The following is a description of a gene set: The chemical reactions and pathways resulting in the formation of a phenol, any compound containing one or more hydroxyl groups directly attached to an aromatic carbon ring. species: Homo sapiens Human Gene Set: GOBP_PHENOL_CONTAINING_COMPOUND_BIOSYNTHETIC_PROCESS, and this is the list of marker genes: INSM1, PMEL, DDT, OPN3, TGFB2, ASIP, DCT, GATA3, CITED1, TYRP1, WNT5A, TYR, SLC7A11, RAB38, RAPGEF2, PNMT, GCH1, MOXD2P, SLC6A3, TPH1, GPR37 (NCBI Gene Id 2861), TH, MC1R, DBH, PAH, TPH2, SLC24A5, KL (klotho, NCBI Gene Id 9365), SLC45A2, CTNS, MOXD1, DAO, OCA2, GIPC1 (NCBI Gene Id 10755), HAND2, TRPC1, PARK7 (Parkinsonism associated deglycase), CDH3, MFSD12, SNCA, VPS35, HDC, NT5DC2, NR4A2, DDC, ATP7A, ALDH2, ZEB2, APPL1 (NCBI Gene Id 26060)